The following is a description of a gene set: Genes having at least one occurence of the motif GTCTACC in their 3' untranslated region. The motif represents putative target (that is, seed match) of human mature miRNA hsa-miR-379 (v7.1 miRBase). Human Gene Set: GTCTACC_MIR379 studied in species Homo sapiens, and this is the list of marker genes: CARF, HBEGF, SLC20A1, CAPZA2, GDF6, SLC22A2, EDEM3, GLMN, ADGRL3, TNRC6B (NCBI Gene Id 23112), UBE2E3, LIN28B (lin-28 homolog B), HTR2C, ZBTB26 (NCBI Gene Id 57684), CACFD1, EI24, ZNF362, SCRT1, TNFSF12, PCGF5, HTR1D, ARHGEF5, EIF4G2